Given this list of marker genes Rabggta, Igfbp3, Zfp420, Prelid1, Casp2 (NCBI Gene Id 12366), Cradd, Rabggtb, Steap3, Triap1, here is a description of the gene set: electronically inferred by orthology from the curated human pathway This event has been computationally inferred from an event that has been demonstrated in another species.<p>The inference is based on the homology mapping from PANTHER. Briefly, reactions for which all involved PhysicalEntities (in input, output and catalyst) have a mapped orthologue/paralogue (for complexes at least 75% of components must have a mapping) are inferred to the other species. Reactome Pathway: TP53 Regulates Transcription of Cell Death Genes species: Mus musculus part of: Transcriptional Regulation by TP53